The following is a description of a gene set: studied in species Homo sapiens Human Gene Set: GOBP_CARBOHYDRATE_DERIVATIVE_CATABOLIC_PROCESS The chemical reactions and pathways resulting in the breakdown of carbohydrate derivative., and this is the list of marker genes: FBXO44, HK1, MGAT1, AOAH, PGAM4, EDEM3, TIGAR, UPP1, NEIL2, LYG1, IDUA, EIF6, FLCN, OVGP1, LYG2 (NCBI Gene Id 254773), INS, NEU1, MIR195, GCK, ENO4, GIT1, GUSB, PDE1A, NEU3, DCTD, PDE4A (NCBI Gene Id 5141), PGK1, BPGM, NCCRP1, PDE4C, SMUG1, ENO2, PSEN1, OGT, GLB1, GBA1, MAPDA, ENTPD7, MANBA, EP300, BTK, MIR16-1, CDA, STAT3, ZBTB7A, XDH, PRXL2C, CEMIP, NT5C, FBXO17, GBA3, NTHL1, CELA1, FUCA2, OGA, PDE5A, PFKM, DUT, UPP2, NEIL1, STT3B, NEU4, PDE4B, NEU2, BCL2L13, NAGLU, SGSH, MFSD8 (NCBI Gene Id 256471), UCHL1, CHI3L1, NCOR1, ALDH1A1, CTBS, CHIT1, MBD4, HKDC1 (NCBI Gene Id 80201), MIR181B1, ENPP4, KAT2B, APP, PDE4D, PKLR, ADAMTS4, MAN1B1, TRIM63, TGFB1 (transforming growth factor beta 1), PRKAA1, STAB2, TYMP, PPP2CA, ENTPD1, ADA2, CST3, GAPDH, FOXK1, MIR127, GSK3A, HTR2A, GALE, PGLYRP3, NUDT16, PPARA, PRTFDC1, GNPDA2, SIRT6, RENBP, TPI1, M6PR, FGF2, CEMIP2, NUDT11, SLC2A6, PRKAG3, SCARB2, APOBEC3G, HPRT1, PNLIPRP2, JMJD8, ADA, SPAM1, UPB1, PDE8A, NT5C2, FBXO27, GPD1L, HYAL3, ENO1, MTCH2, GAPDHS, SUMF1, ALDOC, FKRP, DCTPP1, GPC1, DPYD, HYAL1, ALDOB, CBFA2T3, UCP2, HEXB, OGDHL, SLC4A4, GALT, HMMR, CTSL, ARL2, GBA2, NAGA, PDE7B, GPD1, PDE8B, ITPA, PDE10A, GNS, LCT (lactase), GDA, HIF1A, LIPA, DPYS, FBP1, UNG, PFKFB2, GNPDA1, NPL, MTOR, HK2, AMPD3, DHTKD1, DDIT4, P2RX7, NT5C1A, MMP12, ADAMTS12, ENPP7, ENO3, MLST8, NUDT1, NUDT18, CHI3L2, PRKAA2, HYAL2, HEXA, OGDH, LDHA, OGG1, PFKFB3, PKM, PGK2, PDE7A (phosphodiesterase 7A), GPI, MTAP, ZBTB20, PFKFB1, SRC, IDS, EDEM2, GALM, TDG, LYVE1, ENTPD4 (NCBI Gene Id 9583), CHIA, PDE9A, HK3, DERA, PGM1, ACTN3, NUDT4, ALDOA, GALK1, NAGK, SLC4A1, PRKCD, PRKACA, EDEM1, NT5E, PGLYRP1, MAN1A1, RPTOR, NUDT9, PFKL, NUDT3, PRKAG2, PGLYRP2, MLXIPL, HPSE, ADPGK, AMDHD2, PFKP, GLA, CD44, GM2A, INSR, DNPH1, NUPR1, FBXO6, HINT1, PGLYRP4, SAMHD1, IER3, TREX1, AICDA, NUDT15, NT5M, GALC, PRKAG1, FUCA1, PNP, NUDT10, NGLY1, FBXO2, COL6A1, NUDT4B, ARNT, HDAC4, SMPD1, HYAL4, IFNG, APOBEC3C, IGF1, PGAM2, PDE2A, FOXK2, PGAM1, CDADC1, HGSNAT, ENTPD5